Given this list of marker genes Med1 (NCBI Gene Id 19014), Rxra, Prox1, Spon1, Cited1, Cited2, Pparg, here is a description of the gene set: Mouse Gene Set: GOMF_LBD_DOMAIN_BINDING Binding to a protein's ligand binding domain (LBD) domain, found in nuclear receptors. In general, the LBDs consist of three layers comprised of twelve alpha-helices and several beta-strands that are organized around a lipophilic ligand-binding pocket. studied in species Mus musculus